Given this list of marker genes Tat (NCBI Gene Id 234724), Ido1, Cbs, Otc, Kyat3, Etfa, Bckdk, Auh (NCBI Gene Id 97915), Aadat, Hpd, Hibadh, Acmsd, Kyat1, Ppat, Oaz1, Blmh, 4930438A08Rik, Sardh, Gcat, Ppm1k, Bckdhb, Got2, Kynu, Lao1, Thnsl2, Nos3, Gpt, Afmid, Mtrr, Hoga1, Gpt2, Hmgcll1, Mccc1, Abat, Pah, Atp2b4, Gls, Bcat1, Arg1, Pipox, Sds, Acad8, Gad2, Uroc1, Ddo, Cdo1, Gcsh, Aldh4a1 (aldehyde dehydrogenase 4 family, member A1), Gad1, Il4i1, Hibch, Gls2, Mat1a, Hgd, Oat, Ahcy, Tdh, Nos2, Amdhd1, Gstz1, Arg2, Acat1, Gldc, Prodh, Hdc, Tha1, Ahcyl, Ivd, Kmo, Scly, Adhfe1, Ido2, Qdpr, Hsd17b10, Csad, Agxt, Ftcd, Ddah1, Asrgl1, Got1, Agxt2, Dlst, Dao, Hal, Aldh8a1, Slc25a44, Bckdha, Hmgcl, Amt, Aldh5a1, Fah, Glud1, Nos1, Acadsb, Prodh2, Tdo2, Mccc2, Aass, Dbt, Aldh6a1, Haao, Bcat2, Shmt1, Etfb, Sdsl, Dld, here is a description of the gene set: The chemical reactions and pathways resulting in the breakdown of amino acids, organic acids containing one or more amino substituents. Mouse Gene Set: GOBP_AMINO_ACID_CATABOLIC_PROCESS studied in species Mus musculus